Given this list of marker genes SH3TC2, HNRNPA2B1, ALS2, VCP, SCYL2, SCO2, MPV17, OPA1, PLA2G6, COL25A1, HSPB8, PSAP, SLC12A6, ARSA (arylsulfatase A), SPG7 (NCBI Gene Id 87549), SMN2, HSPB1, TBCK, ASAH1, ERGIC1, HINT1, HNRNPA1, TBCE, DCAF8, FBXO38, PRPS1, SMN1, MFN2, here is a description of the gene set: Evidence of chronic denervation on electromyography. studied in species Homo sapiens Human Gene Set: HP_EMG_CHRONIC_DENERVATION_SIGNS EMG: chronic denervation signs